Given this list of marker genes HSPA6, HSPA1A, RBBP7, HSBP1, HSPA1B, HSBP1L1, here is a description of the gene set: species: Homo sapiens Any process that increases heat tolerance of an organism in response to high temperatures. Human Gene Set: GOBP_HEAT_ACCLIMATION